The following is a description of a gene set: species: Mus musculus Mouse Gene Set: BOYLAN_MULTIPLE_MYELOMA_D_UP from publication Boylan KL, Gosse MA, Staggs SE, Janz S, Grindle S, Kansas GS, Van Ness BG (PMID 17483317) Multiple myeloma is an incurable plasma cell malignancy for which existing animal models are limited. We have previously shown that the targeted expression of the transgenes c-Myc and Bcl-X(L) in murine plasma cells produces malignancy that displays features of human myeloma, such as localization of tumor cells to the bone marrow and lytic bone lesions. We have isolated and characterized in vitro cultures and adoptive transfers of tumors from Bcl-xl/Myc transgenic mice. Tumors have a plasmablastic morphology and variable expression of CD138, CD45, CD38, and CD19. Spectral karyotyping analysis of metaphase chromosomes from primary tumor cell cultures shows that the Bcl-xl/Myc tumors contain a variety of chromosomal abnormalities, including trisomies, translocations, and deletions. The most frequently aberrant chromosomes are 12 and 16. Three sites for recurring translocations were also identified on chromosomes 4D, 12F, and 16C. Gene expression profiling was used to identify differences in gene expression between tumor cells and normal plasma cells (NPC) and to cluster the tumors into two groups (tumor groups C and D), with distinct gene expression profiles. Four hundred and ninety-five genes were significantly different between both tumor groups and NPCs, whereas genes were uniquely different from NPCs in tumor group C and genes were uniquely different from NPCs in tumor group D. Similar to human myeloma, the cyclin D genes are differentially dysregulated in the mouse tumor groups. These data suggest the Bcl-xl/Myc tumors are similar to a subset of plasmablastic human myelomas and provide insight into the specific genes and pathways underlying the human disease. Genes up-regulated in group D of tumors arising from overexpression of BCL2L1 and MYC in plasma cells., and this is the list of marker genes: Zfp839, Nsmf, Snhg12, Fstl1, Bcap29, Arhgap29, 4921525O09Rik, Rrm2b, Rwdd3, Slc35f2 (solute carrier family 35, member F2), Nefh, Dglucy, Lmnb2, Agtpbp1, Pik3ip1, Adat1, Fam221a (family with sequence similarity 221, member A), Arl4a, Timm9 (NCBI Gene Id 72642), Bach1, Napsa, Slc47a1, Clba1, L3mbtl3, Nfix, Lrig3 (leucine-rich repeats and immunoglobulin-like domains 3), Sertad4, Usp15, Tln2, Pdzd2, Ydjc (NCBI Gene Id 71659), Clmn, 2900026A02Rik, Ccr7, Hspb1, Mir1949, Eqtn, Exosc6, Dync2i2, Polr1a, Adgrl2, Sh3bgrl2, Cox6a2, Cpm, Susd3, Prss23, Akt3, Obscn, Adm, Chd4, Irf2bp2 (NCBI Gene Id 672960), Asph, Blvrb, Klf9, Isl1, Cinp (cyclin dependent kinase 2 interacting protein), Ppm1a, Pcp4, Cpn1 (NCBI Gene Id 93721), Slc15a3, Chst7, Prodh, Nipa1, Zfp507, Ptpdc1, Trmt61a, Dhcr24, Clec2i, Clybl, Rapgef6, Plk2, Myc, Bag5, Itga6, Ddit3, Tgs1, Fut11, 1700097N02Rik, Gart, Slc49a4, Mxra8, Ccnd1, Setd4, Afap1, Nrf1, Eif5 (eukaryotic translation initiation factor 5), Spats2 (spermatogenesis associated, serine-rich 2), Ggct, Fabp5, Gsto1, Gphn, Coa8, Spire1, Ebf3